Given this list of marker genes Fgfr3, Grb10, Pik3r2, Fgf20, Pdpk1 (3-phosphoinositide dependent protein kinase 1), Mapk3, Fgf8, Pik3ca (phosphatidylinositol-4,5-bisphosphate 3-kinase catalytic subunit alpha), Fgf16, Fgfr4, Fgf17, Fgf23, Insr, Fgf15, Fgf4, Fgf9, Kl (klotho), Them4, Sos1, Ins1, Pik3cb, Pik3r4, Fgf2, Fgfr1, Fgf3, Akt2, Shc1, Irs2, Pik3c3, Fgf6, Frs2, Trib3, Mapk1, Fgf10, Pik3r1, Flt3l, Fgf22, Ptpn11 (protein tyrosine phosphatase, non-receptor type 11), Grb2, Fgf7, Fgf18, Fgf5, Tlr9, Gab1, Klb, Fgf1, here is a description of the gene set: Insulin receptor signalling cascade Mouse Gene Set: REACTOME_INSULIN_RECEPTOR_SIGNALLING_CASCADE species: Mus musculus